The following is a description of a gene set: In this study, an extensive analysis was conducted to define meta-programs (MPs) capturing intra-tumor heterogeneity across a spectrum of tumor types. The approach utilized non-negative matrix factorization (NMF) to analyze each cell type separately within individual tumor samples. This involved the analysis of malignant cells, macrophages, fibroblasts, endothelial cells, epithelial cells, T-cells, and B-cells. NMF was executed with varying parameter values (K=4, 5, 6, 7, 8, 9), thereby generating 39 programs for each cell type per sample. Each NMF program was summarized by the top genes based on NMF coefficients.\nRobust MPs were then delineated for each cell type using a set of stringent criteria, including recurrence within the same tumor, similarity to programs in other tumors, and non-redundancy within a tumor. Subsequently, these robust NMF programs were clustered (per cell type) based on Jaccard similarity, leading to the identification of MPs associated with each cell type.\nTo enhance the quality of the MPs, a refinement steps were undertaken, involving the removal of MPs suspected of reflecting low-quality data (with an overrepresentation of ribosomal proteins or mitochondrial-encoded genes), single-study inclusion, or similarity to miss-annotated cell types. species: Homo sapiens Human Gene Set: GAVISH_3CA_METAPROGRAM_FIBROBLASTS_MHC_II_CYTOKINE from publication Gavish A, Tyler M, Greenwald AC, Hoefflin R, Simkin D, Tschernichovsky R, Galili Darnell N, Somech E, Barbolin C, Antman T, Kovarsky D, Barrett T, Gonzalez Castro LN, Halder D, Chanoch-Myers R, Laffy J, Mints M, Wider A, Tal R, Spitzer A, Hara T, Raitses-Gurevich M, Stossel C, Golan T, Tirosh A, Suvà ML, Puram SV, Tirosh I (PMID 37258682) Genes upregulated in subsets of cells of a given type within various tumors, and this is the list of marker genes: CCL19, CTSH, CLU, ADRA2A, RRAD, RBP5, CXCL1, RARRES1, RAMP3, ABI3BP, TGM2, SERPINB9, HLA-DRA, FRZB, FMO1, TMEM176A (transmembrane protein 176A), CYP1B1 (cytochrome P450 family 1 subfamily B member 1), VCAM1, CHI3L2, CCL21, UBD, LXN, CD74, ACOT7, TNFSF13B, HSD11B1, DEPP1, CCN1, C3, RGS16, SOD2, TMEM176B, CXCL13, LAP3, CXCL12, PTGDS, APOE, BIRC3, CTSS, CD24, DNAJB1, C7, CCL2, TIMP1, CXCL14, CLSTN3, SOCS3, CHI3L1, HLA-DRB1, IER3